Given this list of marker genes Ext1, Rgs9, Rho, Cat, mt-Nd3, Frmpd1, Slc24a4, Cntnap2, Gnb5, Prph2, Rdh13, Gnat2, Akt2, Kcnc1, Kcnc2, Gpsm2, Gnat1, Scn11a, here is a description of the gene set: species: Mus musculus Mouse Gene Set: GOBP_RESPONSE_TO_LIGHT_INTENSITY Any process that results in a change in state or activity of a cell or an organism (in terms of movement, secretion, enzyme production, gene expression, etc.) as a result of a light intensity stimulus.